Given this list of marker genes NF2, BFSP1, OCRL, FZD5, KIAA1549, MIP, COL18A1, OPA3, PAK2, CRYGS, PANK4, ZNF408, here is a description of the gene set: A cataract which affects the layer of the lens surrounding the nucleus, i.e., the lens cortex. It is identified by its unique wedge or spoke appearance. Human Gene Set: HP_CORTICAL_CATARACT Cortical cataract studied in species Homo sapiens